Given this list of marker genes Nmnat3, Nampt, Nmnat1, Nmnat2, Nnmt (nicotinamide N-methyltransferase), here is a description of the gene set: The chemical reactions and pathways involving nicotinamide, pyridine-3-carboxamide, the amide of nicotinic acid. It is a member of the B complex of vitamins and occurs widely in living organisms. studied in species Mus musculus Mouse Gene Set: GOBP_NICOTINAMIDE_METABOLIC_PROCESS